The following is a description of a gene set: Human Gene Set: GOCC_PROTON_TRANSPORTING_TWO_SECTOR_ATPASE_COMPLEX_PROTON_TRANSPORTING_DOMAIN A protein complex that forms part of a proton-transporting two-sector ATPase complex and carries out proton transport across a membrane. The proton-transporting domain (F0, V0, or A0) includes integral and peripheral membrane proteins. species: Homo sapiens, and this is the list of marker genes: RNASEK, ATP6V0E2, ATP6V0B, TCIRG1, ATP5MC1, ATP5MC2, ATP6V0D2, ATP6V0D1, ATP6V0A1, ATP5MC3, ATP6V0A2, ATP6V0E1, ATP6V0C, ATP6AP2, ATP6V0A4